The following is a description of a gene set: This event has been computationally inferred from an event that has been demonstrated in another species.<p>The inference is based on the homology mapping from PANTHER. Briefly, reactions for which all involved PhysicalEntities (in input, output and catalyst) have a mapped orthologue/paralogue (for complexes at least 75% of components must have a mapping) are inferred to the other species. part of: Conjugation of carboxylic acids Reactome Pathway: Conjugation of phenylacetate with glutamine studied in species Mus musculus electronically inferred by orthology from the curated human pathway, and this is the list of marker genes: Acsm2, Acsm1